Given this list of marker genes ACVR2B, CDC42, NIPA2, GDF1, GPC4, NODAL (NCBI Gene Id 8114), DHCR24, TUBG1, CFAP53, DAW1, NIPA1, RPS15A, ZIC3 (Zic family member 3), MMP21, GPC3, WT1, here is a description of the gene set: Total anomalous pulmonary venous return Human Gene Set: HP_TOTAL_ANOMALOUS_PULMONARY_VENOUS_RETURN Total anomalous pulmonary venous return refers to a congenital malformation in which all four pulmonary veins do not connect normally to the left atrium, but instead drain abnormally to the right atrium. species: Homo sapiens